Given this list of marker genes PLK4, APC2, KAT6B, ADGRL1, ZEB2, PPP1R12A, DCX, GGT1, TRAPPC14, NUP37, TUBGCP2, COPB2, AKT3, KATNB1, DHCR7, CDK6, MCPH1, ASXL1, FMR1, FKRP, TMEM107, ALDH6A1, CPLX1, CIT, PYCR2, POMK, SLC4A10, PEX1 (NCBI Gene Id 7788), KIF14, COL4A2, KAT8, NEDD4L, PAFAH1B1, B4GAT1, MTOR, KIF2A (kinesin family member 2A), PEX14, DHX16, METTL5, TUBA1A, ARF1, POMT2, VPS35L, PPFIBP1 (PPFIA binding protein 1), OFD1, LMBRD2, DCHS1, CEP135, PIK3CA, KNL1, MAN2C1, FAT4, ASPM, BLTP1, CEP152, ANKRD11, RALGAPA1, MAST1, ERMARD, CSGALNACT1, TRAPPC10, KANSL1, CEP85L, PLCH1, WDR62, POMGNT1, MPDZ, PRORP, FGFR3, TBC1D24, TMTC3, AKT1, C2CD3, WARS1 (tryptophanyl-tRNA synthetase 1), MFSD2A, CDK5RAP2 (NCBI Gene Id 55755), NCAPD3, CEP63, RNU4ATAC, SLC25A24, ADD3, GPSM2, STIL, ACTB, RAP1B, ANKLE2, LAMB1, PDHB, USP18 (ubiquitin specific peptidase 18), SPEN, POMT1, MAN1B1 (mannosidase alpha class 1B member 1), GMPPB (NCBI Gene Id 29925), RNU4-2, LAMA1 (laminin subunit alpha 1), FLNA, ZSWIM6, EML1, HNRNPK, SARS1, CDH2, ALG11, RTTN, ARFGEF2, TUBB, SASS6, INTS8, TUBG1, CENPE, MED12, MLH1, ZNF292, FKTN, EPG5, MCM7, ZMIZ1, HYLS1, CPLANE1, PMS2, PHC1, CRB2, TUBB2B, ARMC9, CSF1R, CRPPA, TAF13, MAP1B, NRCAM, here is a description of the gene set: Heterotopia or neuronal heterotopia are macroscopic clusters of misplaced neurons (gray matter), most often situated along the ventricular walls or within the subcortical white matter. Gray matter heterotopia Human Gene Set: HP_GRAY_MATTER_HETEROTOPIA species: Homo sapiens